Given this list of marker genes OPTC, IFT80, BGN, OGN, PBXIP1, EPYC, here is a description of the gene set: studied in species Homo sapiens The process whose specific outcome is the progression of articular cartilage over time, from its formation to the mature structure. Human Gene Set: GOBP_ARTICULAR_CARTILAGE_DEVELOPMENT